Given this list of marker genes Dpp4, Gip, Pomc, Exoc1, Ins1, Ctsg, Pcsk1, Inhbc, Cga, Cma1, Exoc7, Ffar1, Gnb3, Ins2, Grp, Ces1d, P4hb, Sec11c, Slc30a8, Gh, Spcs2, Bche, Lep, Atp6ap2, Enpep, Inhbb, Gnat3, Cpa3, Slc30a5, Spcs3, Inhba, Fshb, Spcs1, Ctsd (cathepsin D), Exoc2 (NCBI Gene Id 66482), Ace, Gcg, Gzmn, Ace2 (angiotensin converting enzyme 2), here is a description of the gene set: electronically inferred by orthology from the curated human pathway Reactome Pathway: Peptide hormone metabolism This event has been computationally inferred from an event that has been demonstrated in another species.<p>The inference is based on the homology mapping from PANTHER. Briefly, reactions for which all involved PhysicalEntities (in input, output and catalyst) have a mapped orthologue/paralogue (for complexes at least 75% of components must have a mapping) are inferred to the other species. part of: Metabolism of proteins studied in species Mus musculus